The following is a description of a gene set: electronically inferred by orthology from the curated human pathway species: Mus musculus part of: Chromosome Maintenance This event has been computationally inferred from an event that has been demonstrated in another species.<p>The inference is based on the homology mapping from PANTHER. Briefly, reactions for which all involved PhysicalEntities (in input, output and catalyst) have a mapped orthologue/paralogue (for complexes at least 75% of components must have a mapping) are inferred to the other species. Reactome Pathway: Nucleosome assembly, and this is the list of marker genes: Smarca5, H4c4, H2ac15, H2ac10, Rbbp7, H2ac8, H2ac13 (H2A clustered histone 13), Hjurp, H2ac23, Cenpn, H2bc22, H4c12, H2ac4, H2bc11, Rbbp4, H2ac11, Cenpu, H2bc7, Cenps, Cenpx, H2ac20, Cenpm, H2ac6, Itgb3bp, H2ac7, H2bc1, H2bc13, H2bc8, H2bc15, H4c6, Npm1, H4c1, H2ac24, H2ac22, H2bc9, H2ac12, H4c8, Oip5, H4c11, Cenpq, H2az2, Cenpa, H2ac1, H4c2, Cenpt, H2bc27, H4c18, H2bc3, H2bc12, H4c3, H2ax, H4c17, H2ac19, H4c14 (NCBI Gene Id 97122), H4c9